Given this list of marker genes Ppp1ca, Fasn, Pcyt1a, Ppp1r3c, Ppp1r3d, Ppp1cb, Ppp1r3e, Ppp1r3b, here is a description of the gene set: studied in species Mus musculus Cytoplasmic bead-like structures of animal cells, visible by electron microscope. Each granule is a functional unit with the biosynthesis and catabolism of glycogen being catalyzed by enzymes bound to the granule surface. Mouse Gene Set: GOCC_GLYCOGEN_GRANULE